Given this list of marker genes ZNF213-AS1, NR5A2, CEP112, LINC00513, SNORD118, CCDC146, RAB11FIP5, GABARAPL1, SCYL2, RAB40C, DAG1, KDM2A, HMCES, KAZALD1, FCF1, NOB1, MACROD1, SH2B1, KAT7, YTHDC2, HAX1, SPECC1-DT, EID1, AGMAT, UBN2, IRGQ, PANK3, UPP1, ACBD3, SIRT2, UQCC6, DNAJC7, NAA15, MYBPC1, SCAF11, L3HYPDH, CLDN23, JUND, SETD9, LAMTOR2 (late endosomal/lysosomal adaptor, MAPK and MTOR activator 2), GPRC5D-AS1, LASP1, LANCL1, PXMP2, UBXN8, HPS5, ST7L, PRDM10-DT, PTPRG, PSTK, NDUFA9, SERTAD3 (NCBI Gene Id 29946), LPIN2, EMP1, NET1, AP1AR-DT, MAGI3, VMP1, ELL3, HSPA8, SOX2-OT, FAM117A, FBXO24, TMEM143, NUP58, HTATIP2, ISCA2, APEH, HDGFL2, ENSG00000267698, ADD3, PCNX3, BRI3BP, HNRNPL, IDE, SNORA78, SERPINI1, TTC41P, MYL6, ADH5, NFE2L2, NME7, NVL, LINC02944, MAP3K14 (NCBI Gene Id 9020), CTCF (NCBI Gene Id 10664), NDUFV1-DT (NDUFV1 divergent transcript), SEPTIN7, MRPS15, TET2, NDUFB5, RTTN, POMGNT1, CTNNBL1, PRKCSH (PRKCSH beta subunit of glucosidase II), TM2D1, SFN, EIF2S2, UBXN4, PTPN2, IER2, NIPAL1, ZNF367, STX10, DESI2, ADIPOR1, IL4I1, FZD1, ATP23, PXYLP1, LCLAT1, ZC3H15, FAM174C, SSU72, CHORDC1, GDAP1, PLD3, FAIM, AMER1, CROT, TDO2, KLHDC10, C2CD2L, ERBB3, REG4, OVCA2, NDUFAF4, FZD3, TLNRD1, ADD3-AS1, PMS1, HNRNPK, EIF3E, SMARCAL1, ADAP2, GTF2H4, ZNF263, DDX6, SLC25A19, C2CD5 (C2 calcium dependent domain containing 5), COX20, COX6B1, MTOR (NCBI Gene Id 2476), ADSS2, NDUFV3 (NADH:ubiquinone oxidoreductase subunit V3), TUBA1C, DYNC2I1, GLRX5, CFLAR, KIF23, DFFB, EEF1E1, SPRY4, SRRM5, STRN3, MZT2B, TRMT112, SAR1A, WEE2-AS1, CCDC51, KANSL1, STK4-DT, LSR, TNPO1, FAM174B, STOX1, PIK3C2A, ANXA2, MRPL16, CC2D2B, PPP4R3A, PAK1IP1, RPS27A (ribosomal protein S27a), CD72, BEST3, HYKK (NCBI Gene Id 123688), JUNB, MMAB, RTN3, RRAS, ENSG00000254531, TMEM106C, SHARPIN, RRP7A, DONSON, INO80D, BBLN, PHPT1, SEPTIN4-AS1, AK3, CEACAM7 (NCBI Gene Id 1087), ATP13A1, KIF2C, STAG3L4, LARP7 (NCBI Gene Id 51574), TTLL12, ALG5, MATCAP1, LRCH4, SLC7A6, UBTD1, ATXN2L, HCFC1R1, HEATR1, SNAPC5, HDAC3, FAM111B (NCBI Gene Id 374393), SKP2, EFL1, UTP18, ERCC6L2-AS1, DDX21, ZFAND4, PEMT, GFI1, SETD4-AS1 (SETD4 antisense RNA 1), ZNF576, ATAD2B, LINC02901, TM4SF5, PRDX5, NEK2, AOPEP, ITPR1-DT, FNBP1P1, NOS1AP, MTO1, ENY2, PRR14L, LINC02313, LRRC46, CLTC, GAU1, CEP20, IQCD (NCBI Gene Id 115811, IQ motif containing D), VILL, ARL4D, OSCAR, BNIP2, CA11, ISY1, MTBP, OSGIN2, SKIC3, MIA2, FAM220A, DPYSL2, NARS1 (NCBI Gene Id 9243), ELF3, LINC01560, ZNF764, CDKN1A, SAMD13, PLEKHJ1, BTN3A2, RAB11A, TRIP10, ZNF3, MIR5700, TXNL4A, TTC14-DT, AP4S1, PJA2, GNB1L, PUM3, TIAL1, DNAJC18, ADGRV1, ENSG00000259403, ARSK, EEF1B2, LINC01133, VEGFA, MFSD14A, EXOSC8, WASHC4, C6orf52, DGLUCY, CGGBP1, KIFC1, KCTD3, GIT2, MIDEAS, LINC01572, RNU6-2, RAB21, RNF32-DT, RAB7A, FBXL8, TRAF4, PRR13, TMEM41B (transmembrane protein 41B), MAP3K4-AS1, TRAM1, MIRLET7IHG, MDN1, GCA, VCF1, LIPE-AS1, TNRC18, VPS39-DT (NCBI Gene Id 105370795), SERTAD1, MIS18A, WDR87, AHCYL2, SHC4, RAET1K, SLC25A28, WDR11-DT (NCBI Gene Id 283089), IMMP2L, SCARB2, SBNO1, SIPA1L3, ATF7IP, CLASRP, ZNF346 (zinc finger protein 346), HSPD1, HMGCL, FARSA, PEX1, PCBP2, ZC3H18, HERC3 (HECT and RLD domain containing E3 ubiquitin protein ligase 3), ZNF394, SP110, GNPAT, SEPTIN7-DT, MRPS27, CD2BP2-DT, FAM185A, TMEM259, LRRC23 (leucine rich repeat containing 23), ANKRD9, FAM110A, ATP6V1E2, SARS2, TSGA10, NCLN, IPP, H2AC10P, RGS17P1, DTL, ENSG00000273162, STK35, SMIM13, PEX11G, HAUS2, C16orf46-DT, PINX1, PSMA3-AS1, CLUAP1, ADIPOR2, SNORD32A, MAN2A1-DT, SNHG21, MRPS10, ABCA2, RNU4ATAC, CENPC, GNA12, ARMH4, SLC22A5, MTERF4, PLEC, PAWR, SLC41A2, ITM2B, PON3, MRPL10, NPC2, CFDP1, KIF9, PRKD2, BRF1, RPL34P1, SNHG10, SH2D6, UGCG (UDP-glucose ceramide glucosyltransferase), TXNL4B, GPN2, BTBD9, NDUFC2-KCTD14, PPCS, TANK, PER1, UBE3C, GLS, NSUN2, RHOQ (ras homolog family member Q), GRHL3, ABHD14B, CLTB, BUD31, PIGN, MAP4, SYNGR4, NDEL1, RUSF1-DT, AJUBA, PPP1R37 (protein phosphatase 1 regulatory subunit 37), CCNT2-AS1, CALM2, SMCR8, ANP32B, RBM34, KIFC3 (NCBI Gene Id 3801), CLCN3 (NCBI Gene Id 133073), METTL17, HINT2, GBA2 (NCBI Gene Id 57704), HBEGF, PET117, DIS3L2 (NCBI Gene Id 282696), COQ8A, RNU5E-4P, GALNS, IQCH, MIR17HG, LTBR (lymphotoxin beta receptor), HNRNPD-DT, PLCXD2, RBMS2, METTL14, SLC3A2, TEDC1, PHF12, PCBD2 (NCBI Gene Id 84105), SUGT1, DCDC1, CSPP1, ZFAND1, ZNF623, NEDD9, TTC23, NUP42, USP42, TRAPPC2L, PPP1R3B, LIN7C, CD276, TIMM44, GRHL3-AS1, LACTB2-AS1, COMMD3, CHCHD1, GAPDH, AARS2, MARF1, MIEF2, WDR83OS, RFESD, NECTIN3 (nectin cell adhesion molecule 3), OSBPL3, MVB12A, ABHD6, GINS3, MIR3651, RPIA (ribose 5-phosphate isomerase A), LAMTOR1, MMUT, MIR4512, LINC01719, WDR33, CNEP1R1, VPS39, KATNB1, AATF, SNORA33, ERLIN2, PPIB, ASCC2, NASP, ZWILCH, C3orf38, SETD4, LRP3, MAPKBP1, COX17, ASAH1, PATL1-DT, STIM2, STAT6, PPP1R10, PCBP4, NXT1, NR1H2, MED16, CS, INTS3, EFHC1, CSNK1G1, CCDC107, CNNM3, HNRNPR, COMTD1, LRRC57, ZNF502, UBXN1, PTGES3, TTC14, MICB, CLDN12, RNASEH2A, FBXL18, NNT-AS1, SLC38A11, NDUFS1 (NADH:ubiquinone oxidoreductase core subunit S1), ERCC6L2, DNAJC19, ATF5, KEAP1, NRXN3, FEM1A, WDR11, LAPTM4A-DT, TOP3A, WDR55, EDEM2, BLTP3B-DT, ELF3-AS1, LINC00511, GAPVD1, SIL1, NEDD1, ZNF252P, MRPL36, PCNX4-DT, NCDN, CA12, NDUFC1 (NADH:ubiquinone oxidoreductase subunit C1), AHSA1, SNRPA1-DT, RBAK, PAPOLA, FLT3LG, PRELID1 (NCBI Gene Id 27166), ENSG00000239137, ASB8, KBTBD4, BLOC1S6, DHODH, KLF14, STX3, POLR3D, MLLT10, TIRAP-AS1 (TIRAP antisense RNA 1), RPN1, FAM185BP, VPS8, ZNF747, XXYLT1, VARS2, TEFM, MYD88, ALAD, MED20, MAT2B (methionine adenosyltransferase 2 non-catalytic beta subunit), DNAJB1, OGFOD1, PRELID2, PHC3, GART, DPH5, ZMPSTE24-DT, ZSWIM3 (zinc finger SWIM-type containing 3), TENT5A, PTPRB, LRRC28, TRIM4, PLA2G15, MGRN1, ZNF143-AS1, PDE8A, MARCOL, STAM (NCBI Gene Id 8027), FANCC, ARHGAP11A, MYCBP, PGAM2, ARFIP2, ADAM17, HIRIP3, TPGS1 (tubulin polyglutamylase complex subunit 1), XKR9, CLASP1, GOLGA2, CTDSP2, C1orf50, APRT, HNRNPD, PAICSP3 (NCBI Gene Id 780810), GAS5, ZNF580 (NCBI Gene Id 51157), CDC37L1-DT, ZMPSTE24, DBI, SRD5A1, RDH10, SYS1-DBNDD2, INTS6, ZFPL1, GTF2H1, TGFB1I1, RELCH, PPIEL, VAMP1, INTS5, HMG20A, PSMG2, MRPL44, NUP62, BOLA1 (bolA family member 1), EBNA1BP2, ZNF41, TIMMDC1, G3BP1, SDR39U1, SEC63, ASH2L, PIK3CA-DT, EIF2AK4, COX6C, ASNSD1, PTPRO, SNORA84, ZNF143, PDRG1, RTRAF, LINC02985, PEAK1, PTCD1, EXTL3-AS1, CENPU, JAK2, ANKHD1-EIF4EBP3, FBXL17, C3orf52 (chromosome 3 open reading frame 52), RIC8A, FALEC, ZFAS1 (NCBI Gene Id 441951), SLC26A2, PCGF6, NDE1, ZCCHC7, MLLT3, TARS2, P3H1, ENSG00000275740, LRIG3, TNPO2, ZNF79, RAB35, BEGAIN, MFAP1, CARS2, MROH8, COQ8B, TDG, DZANK1, MIR616, RMI1, PSMD14-DT, ATXN7, ATP5MJ, ZNF593, NAA50P2, AVPI1, PTPMT1, IL33, ATP5F1A, ST7, RPL4, PAFAH2, RASGRP3, CDK13-DT, HECTD4, RPL13P5 (NCBI Gene Id 90564), MOSPD3 (motile sperm domain containing 3), NPAT, RGS9, DARS1, EPCAM-DT, VPS33A, MTMR11, DHX16, FOXP1-DT, MRPL13, MITD1, ASAH2B, SLTM, CASC11, SYCE2, RNU6-952P, FUZ, NBEAL1, API5, SMAD1, GCC1, LONP1, ARHGAP11A-DT, JKAMP, PLEKHA6, LMAN2, RNPS1, DRG2, ZFP64, FHIP1B, SP3, ZNF398, FOSL2, PMS2P4, NADK2, NDUFS5, GRPEL2, RPL41, IDH1-AS1, EIF3F, PSMB10, SEPTIN7P1, DEPDC1-AS1, HOXA9, DCAF17, ABHD12, SLC38A1, AAGAB, LTN1 (NCBI Gene Id 89753), CTNNA1, SLCO5A1, MLH1, ZNF564, PRPF18 (NCBI Gene Id 8559), ASRGL1, PRKRIP1, TOMM22 (NCBI Gene Id 56993), PGBD1, CDK13, SF3B3 (splicing factor 3b subunit 3), FOXM1, ZSCAN22, LZTR1, LINC00938, CSNK1G3, ZNFX1, ITGB5, PPM1B, STPG4, WDR83, NEK9, ALKBH8, ARID4A, BIVM, LINC02435, LINC02405, LRP6, HOXA-AS2, CFL1, C2orf15, THOC6, TDP2, FAM133B, DPP3, SMCHD1, THAP8, ADGRF3, ZGRF1, DPP3-DT, TP53I3, DZIP1L, LTBP1, FAM174A-DT, DPH5-DT, ARHGEF18-AS1, RNF149, RLF, COG4, ODAD3, ELAC2, ANKHD1-DT, RPS27L, LINC01144, MAN1B1, DNAH8-AS1, UIMC1, C12orf76, SHOC2, MRPL18, SNRPB, NCKAP1, MTERF3, IFT172, LIX1L, ARFGAP2, TRIM41, ARMC5, CTNNA1-AS1, ATP10B, TMEM203, CATSPERD (NCBI Gene Id 257062), SLC2A4, GHITM, MPZL2, MAN1B1-DT, PATL1, IP6K2, CENPP, VAPA, MED4, ESD, NUP93-DT, GAK, DHX37, TP53INP2, PPM1A (protein phosphatase, Mg2+/Mn2+ dependent 1A), TIMM10B, ASXL2, KHDRBS1, RNF187, APTR, OTULIN, GAS2, VRK2, SNX11, RUNDC3B, GOLGA7, UTP3, EXOG, SEMA4B, THADA, MALINC1, SEPTIN2, ACYP1, TMED10, CACUL1, PHB1, MED8, CKAP5, GSTO2, EPDR1, SELENOI, TRAPPC6B, SLC25A26, APAF1, NPDC1, IDH3A, MCCC1, AMZ2P1, B3GNTL1, PRC1, RNF10, CAGE1, PLAG1, ATRN, EWSR1, PCK2, C1QTNF6, PRMT5, TMEM266, ABHD14A-ACY1, PHLDA1-DT, ISCU, LRP4-AS1, TPT1, PHF14, TUBB, BRIP1, ESYT1, SLC12A9, KDM4C, NBAS, PANK2-AS1 (PANK2 antisense RNA 1), REPIN1, CEP250, CFTR, NOL8, HIBCH, OS9 (OS9 endoplasmic reticulum lectin), PIPOX, FADD, LINC02166, TMEM198, POLR2J4 (NCBI Gene Id 84820), NARF, WDTC1, FPGS, SLC37A1, UQCR11, BORCS8, CLNK, ZNF747-DT, FAM117B, CCNJL, MTHFSD, ZFHX3-AS1, SLBP, HNRNPH3, WDR26, GCHFR, TOR1AIP1, GNG12, CBX3P2, UBE2L6, CUTALP, ISY1-RAB43, CBFB, THEM4, THBS3-AS1, RNU6-450P, DNAJC24, UBC, ATP7B, ASCC3, STOML2, FTH1 (NCBI Gene Id 92182), PPP2CA, MMADHC, UEVLD, MTG2, COQ4, ADPRHL1, SH2D5, ZNF546, MAP3K11 (NCBI Gene Id 4296), LINC01852, ATRAID, CHMP4C, POLR2K, TIGD2, GTF2A2, SH3BGRL3, GAS5-AS1, RSPH1, TMEM11-DT, CASP2, PURA, DEPDC4, RPP25L, RTEL1, PDE4D, THUMPD3-AS1, TMA7, CYB561, FOXP1, PINX1-DT, SLC25A12, ZBTB37, OTULIN-DT, CLHC1 (NCBI Gene Id 130162), HSPA6, INKA1, GULP1, VCPIP1, CHEK1, SRSF5, ASAH1-AS1, ANKRD46, C19orf47 (NCBI Gene Id 126526), HEXIM1, MIA2-AS1, ARID2, PRR5L, RPAIN, SLC5A6, NOP2, MTERF1, AAK1, MTDH, PHRF1, CPSF4, STC2, SLCO5A1-AS1, SPAG7, GPR108, IGFL2, RTEL1-TNFRSF6B, ALG11, POLK, ZNF25-DT, RNU6-9, MYO6, NDUFS3, PEX10, TRIM37, TYMP, TAPBPL, RPS18, ALKBH6, FGFR4, WDR5 (NCBI Gene Id 11091), CDC73, FBXW11, PPIAP31, QRICH1, ADO, APBB2, GABPB2, CCNT2, SPAG5-AS1, PCF11, FAM184A, TBC1D32, LINC01749, NDUFC2, S100A2 (NCBI Gene Id 6273), SDF2, KANSL3, C7orf50, LRRC1, NDUFA3, PIGO-AS1, INO80, EPC2 (enhancer of polycomb homolog 2), RPL7, SOCS2, ENTPD1-AS1, PAPOLG, FAM111A-DT (NCBI Gene Id 101927204), SCAANT1, C11orf65, PHLDB1, POP7 (POP7 homolog, ribonuclease P/MRP subunit), TRIP6, SUGT1-DT, MORF4L2, BLZF1, JMJD7, GPR3, MVK, CZIB, ORMDL1, BBIP1, SLC25A35, SPECC1, GRK6, COPB2-DT, PIGO, SRPK2, VIPAS39, ARPC2, FIP1L1, ZNF526, CLINT1 (clathrin interactor 1), PCSK5 (NCBI Gene Id 96284), ABCB8, SAFB, TWSG1, HSPE1-MOB4, MRPS18A, USP3, NAV1, STXBP3, UQCRH, PPP3CA, H2BC10, ESRP2, WIPF2, GARNL3, MIR5696, WDTC1-DT, TMEM248, NAPA, ZSCAN20, MIRLET7I, ATPSCKMT, RASSF6, PPAN, ATM, TUBGCP6, FZD4, SEC23A-AS1, PSMD11, ZNF280D (NCBI Gene Id 54816), KTI12, HIPK3, ING1, NAA16, C1orf122, MYBBP1A, IMPA2, POGLUT2, RNY4, TPCN1, AMACR, NDUFS6, HSD11B1L, PGAM5, SF3A2, SPPL3, NNT, GET1, CFAP418, DPY19L4, BRPF1, TBC1D8, CCT5, DPP9, DNAJC4, GNG12-AS1, CCDC112, TMEM8B, ULK3, MBOAT7, HDLBP, FAF2 (Fas associated factor family member 2), LINC03060, SND1-DT, SENP2, VPS52, RFC1, C17orf75, NUDCD1, AGPAT5, SMG9, RRM2, CNPY2-AS1, CANX, ITPRIP, TMEM14C, EEF1E1-BLOC1S5, RHBDD3 (rhomboid domain containing 3), ESRRA, CD2BP2, CLDN16, TPD52, UBQLN4, FUS, ACTR2, H4C4, TBPL1, NUP88, SAFB2, HMGB3P22, CALM1, ENO1-AS1, DDOST, MORF4L2-AS1, LINC02026, ANO6, NPC1, ZNF354B, KCTD16, TMEM44, EDN1, SAC3D1, ERCC6, R3HDM2-DT, GFM1, POU2F1, SLC38A9, MYG1, KDF1, CRIPT, FAM76B, OSBPL11 (oxysterol binding protein like 11), CDC42SE1, PACSIN2, CEP57, CCDC6 (coiled-coil domain containing 6), RBM27, COMMD6, GINS1, PYM1, MON1B, SUV39H2, SUN1, ARK2N, RSBN1L, NYAP1, CLK3 (CDC like kinase 3), ARAF, EMC2, SPOP, PVT1, PFDN4, KLHL18, ZC3H10, RCC1, SYS1 (NCBI Gene Id 90196), SKA1, MRPS22, RPL29, RPS6KA4, PLSCR1, MRPS12, WDR82, ANO7L1, ANKHD1, SWI5, JUP, ETV6 (NCBI Gene Id 4348), JADE1, EEFSEC, ZNF445, FAM111A, BANF1, ZCRB1, PPP1CC, OGG1, ZC2HC1C, LRCH3, NCBP2, BMS1, CFAP69, C16orf95, PRPF4, PSRC1, CCDC77, ZMYND12, PPHLN1, UQCRFS1, FUT8, MUS81 (NCBI Gene Id 80198), AQR, ZNF672, BCAR1, MSX2, IER3IP1, PDCD10, DYNC1LI1, KIF5B (NCBI Gene Id 3830), LRRC49, TSSC4, RAF1, GATC (NCBI Gene Id 283459), PRKAG1, MSRB1, ZNF740, PTDSS1, SLC19A1, SNX18, WTAP, RMDN2, TANK-AS1, SNORD27, EGLN1, M6PR, COX5A, METTL8, RPS2, TRABD2A, VCL, IFIH1, KIAA0319L, RSRP1, TYSND1, ZNF335, JMJD7-PLA2G4B, RPL26L1, PRRT3-AS1, TBC1D19, ARL4A, SMYD5, SMG5, ZNF169 (zinc finger protein 169), DCTPP1, MIR4482, TMEM68, ENSG00000273828, TIMMDC1-DT, ZNF770, SH2B3, ZNF426-DT, YIPF5 (Yip1 domain family member 5), SSB, EHBP1, SEPTIN9, STX7, BORCS8-MEF2B, SIPA1, KAT14, ARHGDIA, AGBL2, GTPBP8, PABPN1, MTHFD2L, MRPL38, ACTR1B, NRGN-AS1, MRPS33, EIF3D, SMARCA2, GDF15, NAB1 (NGFI-A binding protein 1), ALDH7A1, IQCC, TWSG1-DT, DGKA, GTF2A1, RAB30-DT (NCBI Gene Id 100506233), NCBP2AS2, USP2, TDP1, TNRC6B, BRF2, SLC25A20, AHSA2P, EML6, CZIB-DT, NDUFS8, LMBRD2 (NCBI Gene Id 92255), ENSG00000246090, MIR4638, UBE2D3-AS1, ST7-OT4, DENND3, NUDT13, TNFRSF21, RELL2, MBTD1, DEPTOR, C4orf36, TSEN34, RUSF1, RHBDD1, SLC35A3, OXCT1, ATG4C, LDLR, N6AMT1, RTKN, ZNF581, NECTIN3-AS1, MARS2, BBS2, COPB2, USP2-AS1, RABGEF1, CSDE1, CCDC32, TBX3 (NCBI Gene Id 91834), CCNF, NAA30, MRPL30 (mitochondrial ribosomal protein L30), COMMD4, ALG1, NUTF2, SMARCAD1-DT (SMARCAD1 divergent transcript), CNNM2, CBX2, RIMKLB, CHPF, SNORD12C, INO80E, SLC25A28-DT, CDIN1, TGS1, SLC35A5, PPAN-P2RY11, MDM4, CCT8, DMKN, CAPZA1, PCBP1-AS1, RRAGC-DT (RRAGC divergent transcript), ATAD5, NDUFAF6, VHL, SOS1, TAF1A-AS1, DRAM1, MPG, TMEM167B, CERT1, CHUK, SLC12A2-DT, KLF6, GTF2A1-AS1, EPM2AIP1, FLJ30679, CD27-AS1, RFXANK, CHASERR, AMZ2, GALNT10, PIK3CA, DHX38, MAF1, NAGK, PSMD3, CENPT, USP22, GPRC5C, SND1, RNU6-142P, REXO2, CCDC186, RPL26, FDFT1, HSP90B1, SLC35C2, NSRP1, SRSF4, SNHG9, ZNF131, CCDC91, TTC3, MAML1, TP53TG1, ZNF444, ZDHHC24, PSMD5, PPIL2, PTTG1, ABCA7, SEC14L1, TMEM11, TOMM22-DT, DEDD2, ACY3, ENSG00000237773, VANGL1, SMC5, GPA33, VEZT, GOLGA4, PHLDA1, SSR2, PAICS, FGD6, HSPA1B, YWHAQ, FAM53C, RNF139-DT, TCF12, UGP2 (NCBI Gene Id 7360), GLYCTK, SETD5, SPRED2 (NCBI Gene Id 200734), RN7SL2, DDA1, EIF1AD, RPL13A, ENSG00000187185, RASSF9, NRDE2, AURKB, FBXO15, CCNI2, TXNIP, KDM5A, APOL2, COPS5, MATR3, MED29, IFT140, ITPR1, CDC37L1, PTPN1, VAV2, LINC01232, SNHG1, DHPS, ENO1, UNC5B-AS1, EZH1, PCNX4, IKBIP, SON, LAMA3, DENND5B-AS1, CDCA5, ADGRE2, ABALON, CAPG, GPNMB, H4C8, TPX2, RBM45, LRRC41, TIMM21, TRIM5, IMPACT, SNORD28, SMARCAD1, OXA1L-DT, RAB5IF, IWS1, SNX3, HOXB9 (NCBI Gene Id 3219), ALG10, MGAT1, LINC02924, NARF-AS2, POLR2H, WDR5-DT, SECISBP2L, BYSL, ACOT13, C1orf53, GRB7, EHMT1, CACNB3, GAPDH-DT, SMKR1, SART3, UVSSA, MANBAL, USP54, TPT1-AS1, PTGER4, VSIG10, BTBD1, TRADD, PCBP1, TXLNA, STK4, DUSP10, MED28-DT, CCNL1, PSMD14, RPA2 (NCBI Gene Id 6118), XPOT, ILF2, AHRR, RASGRP2, RSPH1-DT, SAR1B, POLD3, DMAP1, COPG1, IFTAP, RN7SL521P, LIPT1, EFCAB14 (EF-hand calcium binding domain 14), SMIM2-AS1, RN7SKP193, MIR5695, PSMF1, CELSR3 (NCBI Gene Id 1951), CCNB2, RPAP1, MTFR1L, ACOT8, PTPA, SRGAP1, ALOX5 (arachidonate 5-lipoxygenase), PDCD2L, FXR2, RPL26L1-AS1 (RPL26L1 antisense RNA 1), BLCAP, CDK12, ANKRD19P, PRKRA, HSP90AB1, NDUFAF1, CDH17, AFF1, CCAR2, SLC29A2, BCL2L15, H1-4, METTL14-DT, PDAP1, RETREG2, TTYH3 (tweety family member 3), ZNF700 (NCBI Gene Id 90592), SSBP1, ZNF213, GUK1 (guanylate kinase 1), LURAP1L-AS1, NUDCD2, ZC3HC1, TAF1A, TENT2, SAXO2, H2AX, ATF6B, UTP11, LINC00471, ABT1, CTDSP1, DPAGT1, NDUFV1, CDHR3, AP3D1, LINC00229, CEP104, ZNF771, MTNAP1, ZNF395, PPAT, GDF5, TMCC2, INTS6-AS1, CALR, STMN3, FOXP2, UBE2D3 (ubiquitin conjugating enzyme E2 D3), RPL10, ZNF426 (zinc finger protein 426), THEM6, TCP1, LINC02331, UQCRC2, GPR89B, ELFN1-AS1, MANF, ENSG00000254718, ARB2A, ANKRD13D, AHI1, RTL10, ZNF25 (zinc finger protein 25), ITGB8, CRY2, PANK2, ANXA4, PSMA4, SMARCC1, OXA1L, ZC3HAV1, ABHD2, NOL6, LINC02926, RNY3, TRAPPC3, C16orf95-DT (C16orf95 divergent transcript), VRK1, SEC11C, MTMR9, ACTN3, RAB30, AP1G1, UBXN2A, PTEN, TCERG1, EBP, C2orf76, TMEM62, MIR3677HG, ZKSCAN2, OTUD5, ENC1, AP1M1 (adaptor related protein complex 1 subunit mu 1, NCBI Gene Id 8907), BAG3, ATOSA, IDH1, PPIAP68, FZD4-DT, H3C8, SZT2, WDR62, TTC12, C1orf74, RBAK-RBAKDN, MOV10 (NCBI Gene Id 57723), AREL1, THAP10, AP5Z1, CNIH3, ARHGEF39, MRPL47, MARK3, RPS9, CD164 (CD164 molecule), PSMD7, TMEM192, EIF2B2, MYL6B-AS1, SPINK6, STIM2-AS1, SEC22B, UBE2V2, RPS6, ZNF252P-AS1, TMEM209, SLC12A2, SAMD4B, ZFAND2A, CHUK-DT, RNU6-808P, MGST3, PPP6R1 (protein phosphatase 6 regulatory subunit 1), ANTXR2, TMEM216, MIR320A, SRSF10, CD320, FAM98B, C16orf46, SNHG17, TMUB1, IFI30, MKRN2, DNASE2, HSPE1, NRDC, MAN2A1, ACSS2, USP8, PLGRKT, TRIM13, SLC66A3, SAP18, here is a description of the gene set: from publication Yevshin I, Sharipov R, Kolmykov S, Kondrakhin Y, Kolpakov F (PMID 30445619) Human Gene Set: FEV_TARGET_GENES studied in species Homo sapiens Genes containing one or more binding sites for (FEV) in their promoter regions (TSS -1000,+100 bp) as identified by GTRD version 20.06 ChIP-seq harmonization.